The following is a description of a gene set: Mouse Gene Set: GOBP_SPERM_FLAGELLUM_ASSEMBLY The assembly and organization of the sperm flagellum, the microtubule-based axoneme and associated structures that are part of a sperm flagellum (or cilium). studied in species Mus musculus, and this is the list of marker genes: Dnhd1, Rsph6a, Cep128, Ccdc159, Gk2, Spag6l, Cfap221, Cfap43, Ccdc146, Cfap65, Cabcoco1, Cfap206, Pfn4, Ttc12, Klc3, Bbs2, Cfap119, Neurl1a, Cfap157, Ift88, Ttll1, Cfap53, Fsip2, Cfap69 (NCBI Gene Id 207686), Cep131, Cfap58, Iqcn, Ube2b, Tpgs1, Zmynd12 (NCBI Gene Id 332934), Cfap47, Misfa, Bbs4, Dnah1, Spef2, Vdac3 (voltage-dependent anion channel 3), Cfap57, Tbc1d21, Akap4, Yif1b (NCBI Gene Id 77254), Mns1, Drc1, Iqcg, Spag6, Drc7, Cfap61, Ccdc38, Lrrc46, Cfap54, Meig1, Pdcl2, Armc2, Dnali1, Cfap97d1, Cfap44, Armc12, Pla2g3, Cfap70, Dzip1, Ift81, Spag16, Poc1b, Bbof1, Ttll5